The following is a description of a gene set: Human Gene Set: MODULE_98 species: Homo sapiens Genes in the cancer module 98., and this is the list of marker genes: ELF4, BCL9, ZNF43, PSMB5, AGFG1, BRD2, ZFP36L1, CCNA2, ESPL1, NFATC4, RUNX3, EWSR1, DGKI, SRSF7, EZH2, PIR, PSMA5, MBD4, RBBP7, EMG1, SLBP, GTF2B, HNRNPR, TAF11, DDX23, ILF2, LMNB1, ZBTB25, PTMA, CENPE, E2F3, HDAC1, CHAF1B, DNMT1, PSMD2, HDAC2, TOPBP1, HNRNPC, COPS8, MSH2, PLK1, NAP1L1, JUN, H2BC12, CBFB, XRCC5, CSNK2A1, GTF2F2 (general transcription factor IIF subunit 2), FANCG, CBX1, SON, TFAP2A, RAD54L, TOP2A, HMGB1, PNN, HNRNPA0, FOXD2, PER1, NRF1, ETV1, MYT1, TFDP1, DLX5, INSM1, WEE1, CHEK1, SRSF3, FOXG1, GTF2I, PPP4C, KHDRBS3, POLR2K, PSMA4, SFPQ, HR, DDX5, TAF4, SLU7, DDX17, PSMD12, SNW1, CMPK1, RFC1, TENT4A, LHX2, NUP42, GTF2H1, NR2F2, SATB1 (SATB homeobox 1), RPA2 (replication protein A2), PCNA, CITED2, ORC5, NUP153, VPS72 (NCBI Gene Id 6944), CBX4, RAD51C, TBP, GADD45A, CPSF6, MCM6, FOS, CDC7, ZFX (NCBI Gene Id 7543), KMT2A, ZNF136, HMGN1 (high mobility group nucleosome binding domain 1), PTTG1, KHSRP, CENPA, NUP107, ZNF146, CCNB1, MAPKAPK3, POLE2, PTTG1IP, KPNA1, BMI1, SNRPA1, CCNA1, KIF23, TLE1, ACTL6A, DCK, PHLDA1, GTF2A2, ZWINT, MLH1, ATF4, MAP2, RAD21, SOX4, PSMC6, BLMH, NCBP2, TAF7, UBE2A, KPNB1, TAF6, DEK, PRPF8, YY1, DYRK1A, CLK2, PAX6, SSRP1, ANP32A, SNRPB2, FBL (fibrillarin), TGIF1, CCNE2 (cyclin E2), CCNO, ATF2, GTF3C2, TRA2B, SRPK2, SMAD5, COIL, MAD2L1, ERCC8, MSX1, CBX5, PSMA2, SAFB, HNRNPH2, SNRPE, RAD51D, PCBP4, ATN1, RNMT, XRCC3, POLE, PSMD10, NME2, THOC1, CALU, PSMC4, DUSP5, E2F1, ACTR1A, KNTC1, GTF2E1, SUMO1, H1-10, CSRP2, KIF2C, HMGB2, NME1, SUPT4H1, HIF1A, SPDEF, ZNF85, KLF6, CCND2, SEC23B, BLM, COPS2, YBX1, PPP1R8, VAMP7, PRP4K, ADAR, HLTF, YBX3, H2AZ1, CENPC, CDK2, NPAS1, CDKN2C, MAZ, CENPF, SRSF6, TCF12, PSMA7, NCAPD2, ARF5, APEX1, SNRPD1 (NCBI Gene Id 6632), CCNT1, DRD2, PSMB7, POP7, RFC4, CCNE1, SNRPC, BUB1, MLF1, ASAP2, MNDA, STAT1, GNL2, ERCC3, CCNB2, RFC2, FXR2, TPR, HOXA13, STAMBP, NDC80, RFC3, GFI1, AP3M2, MYC, POLD1 (NCBI Gene Id 5424), SMARCC1, SRSF10 (serine and arginine rich splicing factor 10), CTCF, MAPK14, MTA1, ZIC1, PIN1, PPP2R5D, TLX2, FOSL1, HNRNPA3P1, SAP30, MLLT3 (NCBI Gene Id 4300), BUD23, SRSF11, H2AC18, RNF144A, POLR2J, TOX4, GLI3, CDC5L, PRIM1, PRKDC, CEBPG (NCBI Gene Id 1054), FUS, CEBPZ, SOX9, SSB, SMC2, ZNF217, HAT1, NOVA1, ZNF117, NAP1L4, MAFG, ZBTB18, RNF4, PMS1, HNRNPF, DSP, AKT1, LMO2, RAN, MYO18A, DR1, ADNP2, TNPO1, ZNF211, ZNF646, RECQL4, H2AX, MYCN, MEIS1 (Meis homeobox 1), TRIP13, ZBTB24, PPM1D, RFX5, HMGN4, PRIM2, SCAND1, LRP8, ILF3, APLP2, RCC1, FOXM1, NEK2, CSTF2, CDC45, TULP3, JUNB, FOXD1, MYBL2, NFYA, CCND3, NELFE, RBBP4 (NCBI Gene Id 91125), ZNF195, DHX9, KATNB1, SETDB1, SNRPG, KRT6B, SRSF2, POLR2D, ORC1, NUP88, H1-2, FEN1, ARID3A, HSF2, EGR1, LIG1, CSTF3, MCM3, KIF22, LSM1, MPHOSPH6, SNRPA, SRSF1, TSN, HSF1, RCAN1, VHL, PRRX2, CHD4, CIAO1, CDK1, RBBP8, CDKN1A, HNRNPA2B1, CHAF1A, SMAD1, UNG, RPA1, NUDT21, POLR2F, NEK4, POU4F1, KRT19, POLD2, ZNF133, CDC25C, CDK7, TAF5, RFC5 (replication factor C subunit 5), NASP, CDKN2A, MAP7, POLA1, FKBP5, STK38, CSE1L (NCBI Gene Id 1434), LIG4, RAD51, KRT17, H2BC21, KMT2D, PCBP1, RAD23A, ACTR1B, BARD1, EGR2, RPA3, ZNF124, PSMD8, IPO7, NUTF2, YEATS4